Given this list of marker genes SLC28A3, SLC22A2, SLC44A4, SLC25A19, SLC25A36, AQP9, SLC29A3, SLC28A1, SLC25A33, SLC29A1, SLC47A1, SLC28A2, SLC19A2, SLC19A3, SLC29A2 (NCBI Gene Id 3177, solute carrier family 29 member 2), SLC22A1, here is a description of the gene set: The process in which a pyrimidine-containing compound is transported across a membrane. A pyrimidine-containing compound is any compound that contains pyrimidine or a formal derivative thereof. Human Gene Set: GOBP_PYRIMIDINE_CONTAINING_COMPOUND_TRANSMEMBRANE_TRANSPORT studied in species Homo sapiens